The following is a description of a gene set: Genes predicted to be targets of miRBase v22 microRNA hsa-miR-4476 in miRDB v6.0 with MirTarget v4 prediction scores > 80 (high confidence targets). Human Gene Set: MIR4476 species: Homo sapiens from publication Chen Y, Wang X (PMID 31504780), and this is the list of marker genes: SHISA6, AK4, CSNK1E, TRMT10B, MED14, LUC7L2, KLHL7, IL18BP, ACVR2B, RUSC1, JCAD, CALCA, DOCK8-AS1, ALOX15, RAB15, CREB3L2, TMEM25, IGDCC4, TFAP2B, XPR1, MPZL2, ALS2, WDR33, SUSD6, MAN2A1, ST6GALNAC5, BHLHE40, SOCS4, TAP2, TNR, FOXJ2, PARP11, E2F7, WDR48, ANKRD13C, TTI2, PDP2, GJA4, GUCY1A2 (guanylate cyclase 1 soluble subunit alpha 2), SATB2, GJB1, FN3KRP, SCN2B, LCT, ADRB3, PCGF3, C6orf136, HMGXB4, REEP4, MSMO1, NALF1, HMG20A, PLSCR1, ACP7, MRPS16, BCL11B, ONECUT2, TAL1, ATP6AP1, WIPF2, TRIM22, UNC80, EEF1AKMT3, FCGR1BP, ABHD2, HNRNPR, ELK4, KRT38, MASP1, BLMH, LENG8, RNF157, KIAA1217, SPOCK1, JMJD8, ZDHHC2, DLG2, TOR1AIP1, HAND1, GID4, PHF8, FBXO41, TSC22D2 (TSC22 domain family member 2), PTAR1, ZC4H2, TRAF3IP1, EHD2, SH2B3, LANCL1, SRGAP3 (SLIT-ROBO Rho GTPase activating protein 3), C9orf152, NABP2, PARPBP, NIPAL3, ATAD2, GNE, ANKRD45, CSTF2T, TMEM138, PABIR3, WASF2, P2RY10, RTKN2, FSCB, NR3C1, PIP4P1, HERC3 (HECT and RLD domain containing E3 ubiquitin protein ligase 3), PIP5K1A, KDM5C, ZFYVE26, C9orf57, OTUD6A, NEBL, PSMD11, NR6A1, HOOK3, EPHA8, TRRAP, RANBP10, ZNF664, GPATCH8, CAMK2D, CEACAM1, BMP3, PHB1, POU3F1, DLEU7, LSAMP, ADGRF2P, C5orf24, TMED4, OSBP, SRGAP2, ZNF609, MLH3, SV2C, CWC27, ZNF585B, C5AR1, CCDC149, SSH2, DCAF7, EBF2, RAB5B, AAK1, NFAT5, UBXN1, ARIH2, HLTF, FGD6, MLLT11, PITPNM3, PGRMC2, TTLL7, MYO5C, NDUFA10, SDK1, POU2AF1, TPTEP2-CSNK1E, ZXDC, RAB6B, KCNK9, DPYSL2, TWIST1, LRIT3, PEAK1, AP1S3, SRCIN1 (NCBI Gene Id 80725), RAB11FIP2, E2F3, FAM222A, MCRIP1, INSM2, FRZB, FAM168A, ZNF169, SNX27, ASTN1, RPA1, CDIP1, TVP23A, CAMK4, NR4A3, USP37, APEX2, ELFN2, UBN2 (NCBI Gene Id 254048), ATOX1, ANGPT4, ADIPOQ, FNDC5, SH3TC2, PHF21A, UBQLN2, MTCL2, PNMA2, VAMP2, TTC13, CDK6, GPATCH2L, SHISA9, BCAM, SLC29A2, MPRIP, GRAMD1B, ZNF709, JPH1, SCAF11, NACC2, ACSL4, VPS26B, HTR2C, CAMKV, C11orf87, ACKR2, LRRTM4, FEM1B, SPMIP5, USP12, RAB5A, SOCS7, KIAA0825, MAP10, GLRB, SMARCD1, SLC7A1, SEC14L1, PRLR, PRRC2B, HOXA3